Given this list of marker genes NEBL, SCUBE3, SKA2, LRRC27, CTNNA1, ATF7IP, AP3M2, MAN1C1, VPS37A, PLEKHB1, ELAVL4, ACVR2B, CYRIB, EGLN3 (egl-9 family hypoxia inducible factor 3), CDIN1 (NCBI Gene Id 84529), RABL2A, RNF212B, ZNF264, RC3H1, ZNF609, CEP135, POGK, NUP98, KRIT1, INO80D, HERC3 (NCBI Gene Id 9838), USP49, PRDM1, ARMCX1, ZDHHC3, NAV3, DDX52, TRIM8, EXOC6B, SUSD1, CBX3, ATP8A1, DLG2 (discs large MAGUK scaffold protein 2), GATA4, RASAL2, ITM2B, HNRNPR, TRA2A, DEPDC4, ZBTB41, STYK1, C11orf87, UNC5C, MN1, STK35, SEC63, TPRG1, PM20D2, IRF9, GCFC2, PRDM4, CNR1, AMER1, GPATCH2, STK39, FBXO45, LMAN1, CCNT1, GALR1, SMG7, KPNA1, KLHL31, TLL2, RBM20, RAB18, ITCH, CEP350, DDO, CSNK1G3, SPTLC3, RABL2B, C4orf33, CFL1, CAP1, IMPACT, TTC14, HELQ, ALDH1A3, RCBTB2, TBCA, SEC22B, PI15, NMNAT2, GLDC, RNF212, C1orf198, FAM120B, NCOA5, ASTN1, MTMR10, CD302 (NCBI Gene Id 9936), FNDC5 (fibronectin type III domain containing 5), TOR1AIP1, ESYT3, SC5D, BTF3L4, HDAC9, ZBTB20, GANAB, DYRK1A, TP53INP2, RBBP4, KATNIP, TMOD2, ALDH5A1, TSR2, MMACHC, ANK2, CBLN4, HOXB2, HLA-DRA, TEAD1, GNAQ, GPLD1, XPO7, SLC16A2, OGA, ERCC1, CTTNBP2, MYADM, WDR36, SPATS2, TSPAN6, LY75-CD302, KTI12, TMEM19, LMBRD2, DEFB132, ARL3, WDR19, KPNA3, SUFU, ZFP36L2, ANO6, TCP1, MACO1, HAUS6, AR, RAB31, HIF3A, ELFN1, PDE1C, TDRD1, GFRAL, C17orf67, ARID4A, DLGAP4, CDH12, BAZ1A, DDX17, CRADD, PDCL3, ITGB8, ZFYVE26, BUB3, STAMBP, VWA5A, GDPD1, DCX, RABL3, LCE2B, PPM1A, FAM98B, POLQ, SETD4, OR2L13, OTUD7B, AGL, KLF8, F9 (coagulation factor IX), EPS15, NRCAM, STXBP5, DOCK5 (NCBI Gene Id 80005), HNRNPK, ATE1, RNLS, SDC1, KRAS, KIF3A, TMEM126B, CAMK1D, MIER3, CLDND1, RALA, PANK3 (pantothenate kinase 3), ARHGEF35, ESRP1, SNX25, AP1AR, CREB3L2, USB1, ZFP36L1, FSD1L, HDGFL3, LMBRD1, XBP1, KIF5B, RARB, METTL13, SLC26A1, here is a description of the gene set: from publication Chen Y, Wang X (PMID 31504780) Human Gene Set: MIR6859_5P Genes predicted to be targets of miRBase v22 microRNA hsa-miR-6859-5p in miRDB v6.0 with MirTarget v4 prediction scores > 80 (high confidence targets). studied in species Homo sapiens